The following is a description of a gene set: HTLV-1 Tax to SRF-mediated transcription. Pathway ID: N00509. Pathway type: Pathogen. Pathway class: nt06160 Human T-cell leukemia virus 1 (HTLV-1). species: Homo sapiens Human Gene Set: KEGG_MEDICUS_PATHOGEN_HTLV_1_TAX_TO_SRF_MEDIATED_TRANSCRIPTION Pathway Definition from KEGG: TAX -> SRF => (FOS,FOSL1,EGR1,EGR2), and this is the list of marker genes: EGR1, SRF, EGR2, FOSL1, FOS